The following is a description of a gene set: Defects in MUT cause methylmalonic aciduria, mut type (MMAM; MIM:251000), an often fatal disorder of organic acid metabolism. part of: Diseases of propionyl-CoA catabolism species: Homo sapiens Reactome Pathway: Defective MUT causes MMAM, and this is the list of marker genes: MMUT, MMAA